Given this list of marker genes PML (PML nuclear body scaffold), MTCL2, ZNRF1, HDAC6, METRN, RIPK1, SHFL, TCF12, SLC9A5, ERI3, TJAP1, SASH1, CD79A, PUM2, ENTPD2, ZNF609, TMCC3, MBTD1, SDAD1, ZNF704, CCDC13, PHF19, NFIX, LAPTM5, PLXDC2, CYP26B1, MKX, P4HA2, TCHH, ADIPOR1, SZRD1, MDGA1, FBXL18, PLEKHM3, USH2A, PLEKHA5, TMBIM1, CRISPLD1, ZNF341, GPR39, EFCC1, MBNL2, RMND1, GIPC3, NKAIN2, TSPAN7, WARS1, RGMA, ZSWIM5, NATD1, RUNX2, NAA80, STK40, SYNDIG1L, ANTXR1, NANOS2, UQCRC2, KIAA0930, TTYH2, GSG1, ZNF705D, MOBP, SELENON, ARID3B, GPR84, ZNF671, ZNF787, CABP7, JADE2, MGAT4A, ADCY10, ADGRD1, WNT5A, EIF5, ERBB2, CLIP2, TAGLN, CDH6, BEND6, TRAM2, ATP2B2, ARNT2, UBAP2L, FBXO17, NPY, PDAP1, CMKLR1, FNIP2, PCSK5, TAB2, SLC25A19, SDC3, MLLT6, MYSM1, HTR6, PHF24, VDR, NIPSNAP1, P2RY2, RPS6KA2, LARP1, TNS4, BAZ1B, PAK5, TSPAN18, SKIL, ITM2C, NCK1, CNKSR2, here is a description of the gene set: Human Gene Set: MIR4656 Genes predicted to be targets of miRBase v22 microRNA hsa-miR-4656 in miRDB v6.0 with MirTarget v4 prediction scores > 80 (high confidence targets). from publication Chen Y, Wang X (PMID 31504780) species: Homo sapiens